The following is a description of a gene set: Ferroptosis Human Gene Set: WP_FERROPTOSIS species: Homo sapiens, and this is the list of marker genes: TXNRD1, SLC39A8, AKR1C3, HMOX1, DPP4, MAP1LC3A, FTH1, MAP1LC3C, BACH1, ATG7, CISD1, LPCAT3, SLC11A2, NOX4, VDAC3, CHMP6, AKR1C2, VDAC2, IREB2, HMGCR, SLC39A14, SLC40A1, GSS, COQ2, GPX4, NOX1, ALOX15, SLC7A11, ACSL3, GCLC, CHMP5, TFRC, SAT2, ACSL1 (acyl-CoA synthetase long chain family member 1), SLC38A1, ACSL6, CP, CTH, NCOA4, ACSL5, ATG5 (autophagy related 5), GCLM, PHKG2, AKR1C1, SLC1A5, PRNP, FDFT1, SLC3A2 (solute carrier family 3 member 2), ACSL4, FTL, STEAP3, GCH1, CBS, MAP1LC3B, CYBB, TP53, AIFM2, HSPB1, POR, PCBP2, PCBP1, FTMT, SAT1, TF